The following is a description of a gene set: studied in species Homo sapiens from publication Fan X, Bialecka M, Moustakas I, Lam E, Torrens-Juaneda V, Borggreven NV, Trouw L, Louwe LA, Pilgram GSK, Mei H, van der Westerlaken L, Chuva de Sousa Lopes SM (PMID 31320652) Human Gene Set: FAN_OVARY_CL11_MURAL_GRANULOSA_CELL Pseudotime analysis using Monocle 3 alpha, that places the progenitor cell population in the middle of a longer trajectory segment, revealed that pGC (CL15) branched to mural GC (CL11) and mature cumulus GC (CL8 and CL3) (Fig. 6a)., and this is the list of marker genes: SERPINH1, MT-CO2, HNRNPDL, OCIAD2, UBE2D1, MAP1LC3A, MYL12A, THAP9-AS1, TRIP6, DNAJA4, ZNF326, PLA2G12A, PGLS (6-phosphogluconolactonase), IGF1R, RBMS1, AHSA1, CRY1, KHDRBS1, TMEM41A, FDPS, DCP1A, P3H2, LRRC8C, DSP, PDLIM1, CFI, DNAJA1, SLC25A3 (NCBI Gene Id 5250), SPINT2, PTTG1IP, MRPS6, TJP1, DSE, PTGER2, KLHL24, HSPA6, IL6ST (interleukin 6 cytokine family signal transducer), PHF6, FKBP9, CCN1, VIM, NFE2L2, CEBPD, ARIH1, JPT1, TOR1AIP2, BAMBI, LEPROTL1, HS6ST1 (heparan sulfate 6-O-sulfotransferase 1), DAPL1, SUGT1, IGFBP2, RGS10, RDX, SUMO1, AVPI1, RANGAP1, BAZ1A, DDAH2, STRAP, PTRHD1, SRSF2, FDFT1, S100B, PLAT, CELF1, ELK1, RPSA, HMGCS1, HOMER1, BCAT1, MYO6, LRAT, MRPL18, DPP7, PPP2CA, SMAD3, FHL2, HSPA8, DDX17, TMSB10, GRIK1, HOPX (HOP homeobox), SOX4, C6orf62, RHOBTB3, HIF1A, HK1, CACYBP, MED13L, HAPSTR1, YWHAG, MIR22HG, PPP1R15A, NDP, FAM177A1, CMTM8, ARPC2, HDAC2, TARS1, PRDX1, RAB5IF, FGD4, MYL12B, ME2, DPYSL3, TCEAL9, PNN (pinin, desmosome associated protein), DSP-AS1, AMH, PPARG, CCT4, MSMO1, GADD45G, TXN2, PPFIBP1, BRD4, PARP11 (NCBI Gene Id 57197), ZFAND2A, EIF3F (eukaryotic translation initiation factor 3 subunit F), HSPA1B, ATF3, KLHDC8A, CAMTA1, MT-CO3, METAP2, DSEL, TCEA3, MACF1, RAB5A, VIT, DST, WIPF3, PIM1, ZC3H11A (zinc finger CCCH-type containing 11A), CCT6A, AKIRIN1, SLC39A8, DCTN6, DAAM1, FXR1, CRNDE, UBC, CHSY1, PHLDA1, MT-ND4, CD59, FOXP1, ACTG1, CLK1, GNAI1, SPRR2F, CCND2, PAFAH1B3, TGIF1, TRIB2, CCN2 (NCBI Gene Id 1490), HSPD1, PRAME, ENC1, SOWAHC, HEY2, PUM1, MAP4K4, TES, CD99, NOP58, HSPA1A, EML5, SRSF11, SNRPN, SLC46A3, MAP3K13, TIA1, PHACTR2, PPP1R12B, ILF3, MT-CO1, LGR4, PRSS23, YAP1, PLAAT3, FAM204A, DIPK2A, TMEM97, SLC16A1, CMTM6, CDK6, DUSP14, VMP1, ETNK1, TCP1, PLOD2, SIGLEC11, GATM, TEAD1, PHEX, RIMKLB, ATXN1, G0S2 (G0/G1 switch 2), ACSL4, KCNQ1OT1, ARF4, TXNRD1, TNNI3, NEXN, VDAC2, SARAF, RIOK3, GRB14, DCUN1D5, STIP1, SLC25A6, IRS2, KPNB1, HSDL2, RBBP6, ARHGAP18, RHBDD2, TRMT112, BAG3, BEX3, MT-ND1, MARCKS, EPDR1, SYNE2, GSTA4, HSP90AB1, TNIP1, HNRNPA1, WASF1, DNAJC7, SLC5A3, ING3, RAB2A (RAB2A, member RAS oncogene family), ITGAV, COL4A1, ATF4, GJA1, TAF1D, TNFRSF12A, BUD31, RNF19A, PLIN3, TENT5A, SFPQ, KTN1, MYO10, PRKAR2B, PMAIP1, VAPA, NDUFB5, SNAPC1 (NCBI Gene Id 6617), FNDC3B, ZNF281, TNPO1, ENAH, UBE2S, SINHCAF, EIF5, KRT18, IRS1, ITSN1, HS3ST1, LIPH, DNAJB4, SMS, GMNN, MDK (midkine), SRPX, EIF3L, MGARP (NCBI Gene Id 84709), TRAPPC4, KRT8, AKAP9, UBXN8, LHFPL2, RASL11B, XIST, CNN2, IRF4, POMP, TSHZ2, TBC1D4 (NCBI Gene Id 9882), FOSL2, SERPINE2, CLIC1, FDXR, HSPE1, MSI2, TXNL1, NECTIN2, MRPL47, HMOX1, USO1 (NCBI Gene Id 8615, USO1 vesicle transport factor), HUWE1, USP22, SLCO3A1, IFI35, PPHLN1, KIF1B, PPP4R2, AFF4, FSCN1, AMOTL2, TSPAN7, EBPL (EBP like), GASK1B, CDH2, RAD23B, MARK3, NDFIP1, NUP214, DNAJB6, PSMA3, IFI27, POR, UBE2H, AZIN1, LPP (LIM domain containing preferred translocation partner in lipoma), TLE3, BMPR2, TSPAN6, LAPTM4B, KIF5B, LY6E, PGM1, FKBP4, BBX, HSD17B1, ATG101, CITED2, LRRFIP2, VCAN, F3, CCT2, CTNNB1, ACIN1, TAX1BP1, WAC, GREB1, FILIP1L, MAGED2, MGST3, YAF2, ANXA6, ZFAND5, FST, PRDM1, H3-3A, CTSC, TM7SF2, EXT1, ANKRD11, SFRP4, IGF2BP2, ELOVL5, EEF1B2, ITGB1, HMGCR, MARCHF5, NR5A2, JMJD6, H1-0, PDLIM5 (NCBI Gene Id 10611), CD55, ARL5B, SLC25A37, HSPH1, PKN2, ACSM3, INSR, RTN4, POLR2J3, ETF1, CENATAC, RBP1, CHORDC1, TUBA1A, USP48, SNCA, LAMC1, TMEM120A, CTNNAL1, BEX1 (brain expressed X-linked 1), ZBTB10, KDM5A, PNRC2 (proline rich nuclear receptor coactivator 2), GARS1, BEX2, STK17B (serine/threonine kinase 17b), LCMT1, CKS2, MT-ND2, MARCHF7, CSRP2, DNAJB1, RHOB, RYBP, PPP1R13L, RBM22, ST3GAL4, RAB1A, EZH2, GPX3, RHEB, SEC31A, PPA1, CHIC2, GSTA1, TCAF1, HNRNPD, IVNS1ABP, PAWR, YPEL2, CRHBP, LMBR1L, PTP4A1, SCD, ABI2, THBS1, SEPTIN10, SELENOP, EPS8, CD47, MTMR2, SRSF3, ATP5MC2, RPS25, MT-CYB, LIMS1, SQLE, KLF6, MT-ATP6, RAB31, CSPP1, HSPA4, HSP90AA1, OTUD7B, RSRC2, SGK1, CKB, MCL1, WWC2